Given this list of marker genes Bcl2, Gzmb, Arpc1b, Sh2d3c, Nop58, Dph3, Il2rb, Klrb1a, Emc6, Nars1, Cfl1, Cotl1, Gimap5, Pam16, here is a description of the gene set: studied in species Mus musculus Mouse Gene Set: CUI_NK_CELL_LIF_RESPONSE_UP Genes positively differentially expressed in cell type: NK cell upon treatment with cytokine: LIF in mouse lymph nodes in vivo. from publication Cui A, Huang T, Li S, Ma A, Pérez JL, Sander C, Keskin DB, Wu CJ, Fraenkel E, Hacohen N (PMID 38057668) Cytokines mediate cell-cell communication in the immune system and represent important therapeutic targets. A myriad of studies have highlighted their central role in immune function, yet we lack a global view of the cellular responses of each immune cell type to each cytokine. To address this gap, the authors created the Immune Dictionary, a compendium of single-cell transcriptomic profiles of more than 17 immune cell types in response to each of 86 cytokines (>1,400 cytokine-cell type combinations) in mouse lymph nodes in vivo. A cytokine-centric view of the dictionary revealed that most cytokines induce highly cell-type-specific responses. For example, the inflammatory cytokine interleukin-1β induces distinct gene programmes in almost every cell type. A cell-type-centric view of the dictionary identified more than 66 cytokine-driven cellular polarization states across immune cell types, including previously uncharacterized states such as an interleukin-18-induced polyfunctional natural killer cell state.